The following is a description of a gene set: species: Mus musculus Enables the transfer of a nucleotide, any compound consisting of a nucleoside that is esterified with (ortho)phosphate, from one side of a membrane to the other. Mouse Gene Set: GOMF_NUCLEOTIDE_TRANSMEMBRANE_TRANSPORTER_ACTIVITY, and this is the list of marker genes: Slc25a24, Slc25a36, Slc25a51, Panx1, Slc17a9, Slc25a31, Slc25a25, Slc25a32, Slc19a1, Slc25a47, Slc25a42, Slc25a17, Abcc4, Slc35b1, Slc25a53, Abcc5, Ank, Slc25a5, Slc25a23, Slc35b3, Slc25a4, Slc25a41, Slc25a19, Slc25a33, Slc35b2, Slc46a2, Lrrc8a, Slc25a54